Given this list of marker genes Vhl, Pdlim4, Kif5a, Acer3, Eif1b, Sh3bp4, Samsn1, Gzf1, Gbe1, Edn1 (NCBI Gene Id 13614), Traf6 (NCBI Gene Id 99098), Me2, Csrnp1, Lhx9, Atp7a, Gapdh, Arl6ip5, Fos, Pou6f1, Slc2a1, Gys1 (NCBI Gene Id 14937), Mmp8, Cdc42ep3, S100a13, Tnfrsf23, Cxcl12, Lmo7, Acap2, Prpf19, Eno1, Zfp143, Vegfa, Pfkfb3, Insig2, Il18, Gadd45g, Tiam2, Tk2, Setx, Arx, Bhlhe40, Ppp1r9b, Cavin3, Lrp5, Bnip3, Zfp36, Hilpda, Cmc4, Fst, Tmprss11d, Capn1, Ccsap, Tgif1, Higd1a (HIG1 domain family, member 1A), Adm, Foxg1, Foxo3, Dap (NCBI Gene Id 70940), Sik3, Cav1, Ifna12, Klhl2, Ankrd1, Myh9, Dusp3, Cacna1h, Mink1, Gprc5c, Mt1, Ccn2, Eno2 (NCBI Gene Id 52283), Mertk, Sgk1, Soat1, Shb, Dusp14 (dual specificity phosphatase 14), Errfi1, Klf4, Cpd (carboxypeptidase D), Pim3, Rbpjl, Nptx1, Depp1 (NCBI Gene Id 71480), Rps6ka5, Lnpep (leucyl/cystinyl aminopeptidase), Prdx5, Dnajc5, Lxn, Noct, Tomm40, Dmp1, Selenbp1, Psmc4, Tcim, Ccn1, Skil, Ssx2ip, Irx1, Spry2, Pgf, Klf10, Nfkbia, Pnrc1, Npepps, Vwa1, Llgl1, Traf3ip2 (NCBI Gene Id 103213), Mmp3, Polr2d, Ppl, Hbegf, here is a description of the gene set: from publication Gross C, Dubois-Pot H, Wasylyk B (PMID 17704799) studied in species Mus musculus The ternary complex factor Net/Elk3 is downregulated in hypoxia and participates in the induction by hypoxia of several genes, including c-fos, vascular endothelial growth factor and egr-1. However, the global role of Net in hypoxia remains to be elucidated. We have identified, in a large-scale analysis of RNA expression using microarrays, more than genes that are regulated by Net in hypoxia. In order to gain insights into the role of Net in hypoxia, we have analysed in parallel the genes regulated by HIF-1alpha, the classical factor involved in the response to hypoxia. We identified about genes that are regulated by HIF-1alpha in hypoxia. Surprisingly, when we compare the genes induced by hypoxia that require either Net or HIF-1alpha, the majority are the same (75%), suggesting that the functions of both factors are closely linked. Interestingly, in hypoxia, Net regulates the expression of several genes known to control HIF-1alpha stability, including PHD2, PHD3 and Siah2, suggesting that Net regulates the stability of HIF-1alpha. We found that inhibition of Net by RNAi leads to decreased HIF-1alpha expression at the protein level in hypoxia. These results indicate that Net participates in the transcriptional response to hypoxia by regulation of HIF-1alpha protein stability. Mouse Gene Set: GROSS_HYPOXIA_VIA_HIF1A_DN Genes down-regulated in SEND cells (skin endothelium) at hypoxia after knockdown of HIF1A by RNAi.